Given this list of marker genes FCN1, CD1E (NCBI Gene Id 913), CD180, CD302, FOS, LPAR6, C1orf162, KIAA0513, C5AR2, BLVRB, SNX30, TMEM97 (NCBI Gene Id 27346), LST1, CISD2, FPR3, RNF135 (ring finger protein 135), TMT1A, C1orf54 (chromosome 1 open reading frame 54), MEF2C, LINC00900, GNA13, ITGB5, PLXDC2, ARHGAP18, RBP7, PDK4, ITGB7, CALCOCO1, PGM2, DRAM2, UBASH3B, UCHL3, AGO1, DIPK2A, HNRNPLL, MERTK, SLCO2B1, DENND1B, TNFSF13B, FAM13A, ACP5, STK38L, HSD17B10, FGL2, CD1C, VSIG4, FN1, LTA4H, SAMHD1, SNRPG, SCARB2 (NCBI Gene Id 950), GLUD1, FUCA2, RERE, COX14, AP2M1, RHOT1, GPR65, FABP4, CD300LB, SUOX, LIPA, TREM2, PLIN2, U2AF1L4, MAN1A2, MACF1, RNASE2, PFKFB4, ZNF137P, APMAP, TACC1, TUSC2, SLC25A20, SRD5A3, DOCK10, GPN3, CASS4, WDR91, CASP10, MFNG, ZDHHC7, CD9, NCKIPSD, INPP5K, DDAH2, DHRS11, GALC, GGA2, MEX3B, PARL, ABHD6, PLA2G15, MYG1, FUCA1, CALHM2, SORD, VMO1, LSP1, DHRS9, HHEX, PPT1, VAMP8, CKS1B, APBB1IP, LGALS9, LINC02035, TMEM39B, SLC22A5, OASL, TIMM8B, TXNIP, ZNF503, FBP1, CDK19, NPL, PHPT1, TNFRSF11A, EVI2B, RNF114, LPCAT2, CD36, CHN2, AVPI1 (NCBI Gene Id 60370), UTRN, MPC1, CPT1A, SLC66A3, FAM168A (family with sequence similarity 168 member A), SLC31A1, UHRF1, RAB7B, TEX2 (testis expressed 2), DNMBP, SSBP4, TUT7 (NCBI Gene Id 79670, terminal uridylyl transferase 7), ABCD3, MNDA, ABHD11, BCKDHA, FAM120A, CD84, RAP1GDS1, RMDN2, IL1R2, FBXO9, TMED10, PAK1, CLEC7A, RCBTB2, AIF1, CEP85, EEPD1, ALCAM, FAM135A, LSM10, IMPA2, IDH3G, SHB, CIAO2A, SLC37A2, MYCL, REV3L, GAS2L3, TRIM14, KIAA0232, TMEM134, CD4, NFXL1, MPP1, ARHGAP6, RNASE1, CD101, A2M, CUX2, PLPBP, RBM15 (RNA binding motif protein 15), RMND5A, SORT1, UQCC5, PON2, DRAP1, CD1D, RASA1, CAMK1, OTULINL, WDFY2, GRK3, GTF2F1, ADAP2, REPS2, PRCP (NCBI Gene Id 5547), SIGLEC16, SLC46A2, PIP4K2A, NTMT1, TIMM10B, CMTM7, here is a description of the gene set: Histone methyltransferases catalyze site-specific deposition of methyl groups, enabling recruitment of transcriptional regulators. In mammals, trimethylation of lysine 4 in histone H3, a modification localized at the transcription start sites of active genes, is catalyzed by six enzymes (SET1a and SET1b, MLL1–MLL4) whose specific functions are largely unknown. By using a genomic approach, we found that in macrophages, MLL4 (also known as Wbp7) was required for the expression of Pigp, an essential component of the GPI-GlcNAc transferase, the enzyme catalyzing the first step of glycosylphosphatidylinositol (GPI) anchor synthesis. Impaired Pigp expression in Wbp7-/- macrophages abolished GPI anchor-dependent loading of proteins on the cell membrane. Consistently, loss of GPI-anchored CD14, the coreceptor for lipopolysaccharide (LPS) and other bacterial molecules, markedly attenuated LPS-triggered intracellular signals and gene expression changes. These data link a histone-modifying enzyme to a biosynthetic pathway and indicate a specialized biological role for Wbp7 in macrophage function and antimicrobial response. species: Homo sapiens Human Gene Set: GSE30971_CTRL_VS_LPS_STIM_MACROPHAGE_WBP7_HET_2H_DN from publication Austenaa L, Barozzi I, Chronowska A, Termanini A, Ostuni R, Prosperini E, Stewart AF, Testa G, Natoli G (PMID 22483804) Genes down-regulated in bone marrow-derived macrophages with heterozygous MLL4 knockout: control versus treated with LPS for 2h.